The following is a description of a gene set: Androgen receptor signaling studied in species Homo sapiens Human Gene Set: WP_ANDROGEN_RECEPTOR_SIGNALING, and this is the list of marker genes: PIK3R2, RACK1, ROCK2, CALR, STUB1, BRCA1, ETV5, RLN1, RELA, SMARCE1, TLE5, SRC, RNF4, ZMIZ1, TGIF1, SMAD3, CARM1, NR2C2, STAT3, KAT7, SMAD4, SIN3A, NCOA1 (NCBI Gene Id 8648), UBE2I, DAXX, BUB1B-PAK6, MDM2, DSTN, PIAS1, SP1, AKT1, CREB1, BAG1, CTNNB1, RUNX2, RNF6, KAT5, RHOA, AR, PLPP1 (phospholipid phosphatase 1), HDAC1, SIRT1, SUMO1, KDM1A, FLNA, SMIM40 (NCBI Gene Id 113523636), NR0B2, FOXO1, RB1, NCOR1, PIAS2, NCOA2, CREBBP, RNF14, PATZ1, EFCAB6, KLK3, EGFR, PIK3R1, PARK7, PAK6, PTEN, PSMC3IP, PIAS4, CDC42, CCNE1, GSK3B, RAN, PRDX1 (NCBI Gene Id 5052), JUN, BMF, LIMK2, FKBP4, RAC1, CCND1, CAV1, RAD9A, UBE3A (ubiquitin protein ligase E3A), NCOA3, ZNF318, TGFB1I1, FHL2 (four and a half LIM domains 2), EP300, RHOB, NCOR2, KAT2B, PIAS3, NCOA4 (NCBI Gene Id 8031), CDKN1A, PTK2, ROCK1